Given this list of marker genes NOS2, IFNB1 (NCBI Gene Id 3456), CREB3L2 (cAMP responsive element binding protein 3 like 2), ITGB2, LAMA2, HIF3A, PPP2R5A, CREB3L1, COMP, NOS3, ITGAV, PPP2CA, MDM2, COL5A2, FGF2, ITGA7, EPO, FGF9, PELO, ITGAX, LPAR5, CREB3, RHEB, SREBF1, FGF3, FLT1, GNB1, ANGPT4, PIK3R5, FGFR1, HGF, JAK2, PDGFD, COL4A6, CDC37, AKT1 (NCBI Gene Id 207), IL2RB, THBS1, ITGB3, PRKAA2, GNGT1, LAMC3, GNG8, ATF4, GNG3, LAMC2, PHLPP1, TSC2, EPAS1, MET, PDGFB, ITGAE, COL4A1, LAMA1, FGF12, RAB8A, COL5A3, KITLG, NGF, ANGPT2, SPP1, FGFR3, ITGAM, FGF4, TSC1, FGFR4, GYS1, IL2, IL7R, TEK, CHRM1, EFNA3, ITGA9, ITGB8, HIF1A, HRAS, PPP2R2D, LAMA3 (NCBI Gene Id 3909), SLC2A2, DDIT4, PRKAA1 (protein kinase AMP-activated catalytic subunit alpha 1), GNB4, PDGFRB, TCL1B, ITGA8, LPAR4, GNGT2, OSM, PPP2R1B, MAPK3 (NCBI Gene Id 5595), EPOR, LAMA4, PDGFC, TNXB, HSP90AA1, THBS3, RAF1, CSF1R, FOXA1, NOS1, MAPK1, FGF21, GNG5, HSP90AB1, EIF4E2, IBSP, TNC, KDR, GNG13, FGF11, THBS4, PDPK1, AKT3, CRTC2, ITGB1, RAB10, RELN, AKT1S1, LPAR2, FGF16, PTEN, VWF, SLC2A4, PDGFA, IRS4, ITGAL (integrin subunit alpha L), IFNA7, CAB39, BAD, EIF4EBP1, CHAD, SOS1, PDGFRA, FGF7, GNG2 (G protein subunit gamma 2), LPAR1, LIPE, ITGA10, PIK3R2, ITGA4, GSK3B, LAMB3 (NCBI Gene Id 3914), LAMC1, PPP2R5B, PIK3CA, PTK2, FOXO1, CREB3L3, PRL, COL4A2, IRS2, EPHA2, PRLR, INSR, MTOR, FGF17, INS, ATF2 (activating transcription factor 2), COL1A2, IL3RA, IKBKG, HSP90B1, TNR, FGF14, COL4A4, STRADA, PPP2R2B, FN1, VEGFD, ATF6B, PFKFB3, ACACA, ITGAD, NRAS, ITGB7, IFNAR1, GNG11, LAMA5, FGF1, RAB2A, FGF20, FGF10, RPTOR, LPAR3, PPP2R3A, EIF4E, SLC2A3, FGF8, EFNA4, SLC2A1, CSF3, RAB14, CASP9, PIK3R1, FOXO3, PPARGC1A, CDKN1B (cyclin dependent kinase inhibitor 1B), JAK3, NGFR, RPS6KB2, VEGFB, COL6A2, EGFR, IL2RA, PIK3CG, ITGB6, IFNAR2, IGF1R, IKBKB, VEGFA, GNG7, FGF18, KRAS, CREB3L4, ANGPT1, FGF19, ITGB5, RPS6, IRS1, PPP2R5E, AKT2, MLST8, IGF1, FLT4, TCL1A, IL2RG (interleukin 2 receptor subunit gamma), VEGFC, COL1A1, TNN, VTN, ITGB4, PIK3IP1, F2R, CSF3R, TBC1D1, PPP2R5C, MAP2K2, COL11A1, LAMB2, ITGA3, EIF4B, CREB5, PIK3CD, GYS2, CAB39L, EFNA5, EGF, GNG10 (G protein subunit gamma 10), PIK3C2B, LAMB1, FGF22, COL11A2, ITGA5, CREB1, FGF13, FGFR2, COL3A1, GNG4, GNB2, EFNA1, STK11, MAP2K1, PPP2R3C, PFKFB2, GNG12, COL5A1, PFKFB4, ITGA6, ELAVL1, PPP2CB (protein phosphatase 2 catalytic subunit beta), ITGA2B, PIK3CB, PPP2R1A, EIF4E1B, THBS2, LPAR6, GRB2, PGF, PHLPP2, RPS6KB1, COL2A1 (collagen type II alpha 1 chain), PIK3C2A, GHR (growth hormone receptor), ITGA2, IL6R, IL4R, CDKN1A, PPP2R5D, OSMR, PPP2R2C, JAK1, RAB11B, CSH1, GNB3, PFKFB1, CSF1, ITGA11, CHRM2, ULK1, KIT, EFNA2, PIK3R4, FGF6, here is a description of the gene set: Human Gene Set: WP_FOCAL_ADHESION_PI3KAKTMTORSIGNALING Focal adhesion: PI3K-Akt-mTOR-signaling species: Homo sapiens